The following is a description of a gene set: from publication Kerkar SP, Goldszmid RS, Muranski P, Chinnasamy D, Yu Z, Reger RN, Leonardi AJ, Morgan RA, Wang E, Marincola FM, Trinchieri G, Rosenberg SA, Restifo NP (PMID 22056381) Myeloid-derived cells comprising the tumor stroma represent a heterogeneous population of cells critical to the structure, function and growth of established cancers. We have recently found that engineering tumor-specific CD8+ T cells to secrete IL-12 (IL-12TD) can lead to striking improvements in T-cell activity against established melanomas in murine models. Surprisingly, IL-12-dependent enhancement of CD8+ T-cell anti-tumor function did not occur through direct ligation of receptors on lymphocytes or NK cells. Instead, IL-12 sensitized host bone marrow-derived tumor-stromal cells, partly through interferon-gamma, to indirectly enhance the effects of adoptively-transferred T cells. Direct presentation of antigen by tumor was not necessary, but MHC class I expression on endogenous cells was essential for IL-12 mediated anti-tumor enhancements. Upon successful treatment with IL-12TD cells, we observed the selective elimination of tumor-infiltrating CD11b+ F4/80+ macrophages, CD11b+/ClassII+/CD11c+ dendritic cells and CD11b+/Ly6C+/Ly6G- but not CD11b+/Ly6C+/Ly6G+ myeloid-derived suppressor cells within regressing lesions. These results are consistent with a model whereby IL-12 triggers the maturation of myeloid-derived cells into competent antigen cross-presenting cells. Licensed recognition of these antigens by effector T cells may in turn trigger the collapse of the tumor stroma and aid in the regression of large vascularized lesions. species: Homo sapiens Human Gene Set: GSE29164_DAY3_VS_DAY7_CD8_TCELL_AND_IL12_TREATED_MELANOMA_UP Genes up-regulated in B16 melanoma during adoptive transfer therapy: day 3 versus day 7., and this is the list of marker genes: EI24, C6orf15, PARN, GPR155, TNFSF9, DHRS7, RRP15, TENT4B, FBXO4, ARHGEF3, FAM217B, ACSS1, TMEM9B, INSIG1, DCUN1D1, TBC1D14, DNAJB2, CD300C, DMPK, HSD17B12, KCNE3, IK, TEX9, ITGA5, LCN2, TSC22D2 (TSC22 domain family member 2), TSEN2, CLOCK, GRPEL1, CSRP2, CD84, TAF15, ABTB2, RASEF, RWDD1, SLC2A6, LGALS3, CAPZA1, TBC1D19, SNRPG, HLA-E, NIT2, IGSF6, L1CAM, CINP (NCBI Gene Id 84716), UPF3B, TTC27 (tetratricopeptide repeat domain 27), TXNDC17, KLHL24, CAMKK2 (calcium/calmodulin dependent protein kinase kinase 2), CCNH, POLR1D, NAA30, PMVK (phosphomevalonate kinase), SMOX, IL7R, NUCB2, SETD6, BABAM1, MADD, RBM43, CHD7, EMC9, CKLF, DBP, CBR4, SAP30BP, DYNLT3, BMPR2, MAN2A2, IQGAP2, CERK, NDUFA13, EPRS1, MBTD1, UXT, CCR2, IST1, CERS5, DDX3X, ZFHX3, GLUD1, GHITM, SKIC8, P2RY10, LPL, ZBTB18, UROD, TENT5A, NFE2, FKBP1B, RSPH3, CCL17, CEP19, USE1, DCTN3, ELAPOR2, PVT1, C19orf12, FZD4, TRA2A, CCT5, PARD6A, LAMTOR5, RCOR3, TMEM192, MGST2, FNIP1, TM6SF1, MX2, COQ3, RNF115, PTPN1, CARD10, ZC3HAV1, STX3, MLLT3, USP18, DCTN6, DENND4A, TET2, C15orf40, IFI35 (NCBI Gene Id 3430), SMIM5, ITGB7, CCT6A, TMEM126A, CD2, PAIP2 (NCBI Gene Id 51247), MAP3K1 (NCBI Gene Id 4214), CYSLTR1, METRNL, ZCCHC9, AKR1B1, ZBTB11-AS1, MSRB1, NGDN, HDAC5, TLR4, DNAJB4, DRAM2, GPR160, VEGFC, RNF24 (ring finger protein 24), BTBD1, BTBD7, MEX3B, RBKS, VDAC3, SEMA4C, NR1D2, LRG1, TATDN1, FLCN, ABRAXAS2, SELENOM, FNTA, ERO1B (endoplasmic reticulum oxidoreductase 1 beta), CHD1, SLC25A37, ENPP2, CFDP1, AKT3, TRPV2, FKBP3, POLG2, CCDC88A, PHB2, MRPL58, WIPI2, NDUFB9, PLAAT3, OSM, STX18, CLU, KLHL22, NDRG1, EXT1, FOXRED2, ZBTB37, LY86, TAF1D, ABCG2, OASL, WAC, YDJC, METTL23, NDUFA2, JMY (NCBI Gene Id 23651), SLC35A1, SLC25A31 (solute carrier family 25 member 31), PEX13, CHSY1 (NCBI Gene Id 22856), COPS2, ELL3, NOSTRIN, TASL (NCBI Gene Id 80231), RPS7, MRPL16, BCS1L (BCS1 homolog, ubiquinol-cytochrome c reductase complex chaperone)